Given this list of marker genes NBDY, CNOT2, CNOT1, PAN2, PATL2, CNOT6L, PAN3, CNOT6, here is a description of the gene set: Any process that modulates the rate, frequency, or extent of the aggregation, arrangement and bonding together of proteins and RNA molecules to form a cytoplasmic mRNA processing body. studied in species Homo sapiens Human Gene Set: GOBP_REGULATION_OF_CYTOPLASMIC_MRNA_PROCESSING_BODY_ASSEMBLY